Given this list of marker genes AVP (arginine vasopressin), DLX6, TLE1-DT (TLE1 divergent transcript), FNDC9, PDYN, RELN (reelin), RARB, ARX, TFAP2D, SLCO6A1, ISL1-DT, DLX2, LINC01324, LINC01305, PAX2, SIM1, DLX1, BMP3, RXRG, LRRC52-AS1, NNMT, LINC02487 (NCBI Gene Id 441178), TFAP2B, LINC01210, DMBX1 (NCBI Gene Id 127343), HMGB1P47, LINC01830, LHX8, TAC3, SHOX, CCK, HTR4, PTCHD4, GPR6, SYNPR, SLC6A5, KCNA1, SCGN, SP8, MME-AS1, BRS3, SYTL5, CRABP1, CENPS-CORT, DRD3, ISL1, DLX5, here is a description of the gene set: Human Gene Set: DESCARTES_FETAL_CEREBRUM_INHIBITORY_NEURONS Marker genes curated from the annotated cluster as represented in the Descartes Human Gene Expression During Development database. from publication Cao J, O'Day DR, Pliner HA, Kingsley PD, Deng M, Daza RM, Zager MA, Aldinger KA, Blecher-Gonen R, Zhang F, Spielmann M, Palis J, Doherty D, Steemers FJ, Glass IA, Trapnell C, Shendure J (PMID 33184181) The gene expression program underlying the specification of human cell types is of fundamental interest. The study authors generated human cell atlases of gene expression and chromatin accessibility in fetal tissues. For gene expression, the study authors applied three-level combinatorial indexing to >110 samples representing 15 organs, ultimately profiling ~4 million single cells. The study authors leveraged the literature and other atlases to identify and annotate hundreds of cell types and subtypes, both within and across tissues. Our analyses focused on organ-specific specializations of broadly distributed cell types (such as blood, endothelial, and epithelial), sites of fetal erythropoiesis (which notably included the adrenal gland), and integration with mouse developmental atlases (such as conserved specification of blood cells). These data represent a rich resource for the exploration of in vivo human gene expression in diverse tissues and cell types. studied in species Homo sapiens